Given this list of marker genes Dsp, Kcnj2, Ctnna3, Sumo1, Ptger3, Cacna1h, Scn5a, Rangrf, Bin1, Cacna1c, Dbn1, Dsg2, Casq2, Nos1, Acta2, Adrb1, Dsc2, Sri (sorcin), Ryr2, Dlg1, Zeb2, Myh7b, Atp1a2, Cav1, Tnnc1, Akap9, Gata4, Stc1, Fgf13, Adora1, Ank2, Trpm4, Jup, Atp1a1, Pln, Mylk2, Adcy10, Fxyd1, Pkp2, Tnnt2, Gja5, Atp2a1, Akap6, Strit1, Pde4d, Pdpn, Hcn4, Atp2a2, Cav3, here is a description of the gene set: Any process that modulates the frequency, rate or extent of actin filament-based movement. Mouse Gene Set: GOBP_REGULATION_OF_ACTIN_FILAMENT_BASED_MOVEMENT species: Mus musculus